Given this list of marker genes Xirp1, Actn1, Sptan1, Ctnnb1, Vcl, Des, Cdh2, Jup, Tln2, Nrap, Ctnna3, Gja1, Dsp, here is a description of the gene set: Mouse Gene Set: GOCC_FASCIA_ADHERENS A cell-cell junction that contains the transmembrane protein N-cadherin, which interacts with identical molecules from neighbouring cells to form a tight mechanical intercellular link; forms a large portion of the intercalated disc, the structure at which myofibrils terminate in cardiomyocytes. species: Mus musculus